Given this list of marker genes GSX2, RHEB, TENM4, DRD3, NF1, ID2, HES1, ZNF488, SOX1, DAB1, NKX2-2, MDK, DUSP10, NKX6-2, MYRF, ZNF365, DAAM2, CXCR4, DLX1, CDK1, ID4, EPHA4, MTOR, DLX2, MIR181B1, TNFRSF1B, BIN1, RNF112, NR2E1, IL6ST, DICER1, QKI, PRMT5, PTPRZ1, HDAC2, HES5, BMP2, MYCN, NKX6-1, TP73, SHH, NOG, PTN, OLIG2, WDR1, TGFB1, MIR142, RELA, SERPINE2, DAG1, TNFRSF21, LIF, OPALIN, TREM2, LDLR, IL34, MAG, SLC45A3 (solute carrier family 45 member 3), GPR37L1, NOTCH1, TTBK1, LIN28A, NTRK3, DUSP15, TMEM98 (transmembrane protein 98), EGR2, F2, CTNNB1, HDAC1, CLCF1 (cardiotrophin like cytokine factor 1), CNTN2, SPINT1, CLCN2 (chloride voltage-gated channel 2), NR1D1, IL6, MIR181C, HMGA2, here is a description of the gene set: Any process that modulates the frequency, rate or extent of glia cell differentiation. Human Gene Set: GOBP_REGULATION_OF_GLIAL_CELL_DIFFERENTIATION species: Homo sapiens